Given this list of marker genes HLA-DQB1, MAPT (NCBI Gene Id 8152), ATP6AP2, PRNP, MICU1, IFIH1, RNASEH2C, ADAR, SAMHD1, OPA3, TAF1 (NCBI Gene Id 6872), LSM11, RNASEH2B (ribonuclease H2 subunit B), RNASEH2A, TREX1, RNU7-1, here is a description of the gene set: Muscular rigidity (continuous contraction of muscles with constant resistance to passive movement). studied in species Homo sapiens Extrapyramidal muscular rigidity Human Gene Set: HP_EXTRAPYRAMIDAL_MUSCULAR_RIGIDITY